The following is a description of a gene set: species: Mus musculus Binds to and modulates the activity of a sodium channel. Mouse Gene Set: GOMF_SODIUM_CHANNEL_REGULATOR_ACTIVITY, and this is the list of marker genes: Fxyd2, Ptpn3, Fgf13, Fgf14, Fxyd6, Scn3b, Nos1, Fxyd3 (FXYD domain-containing ion transport regulator 3), Pcsk9, Fxyd5, Scn4b, Ywhah, Tmprss3, Gpd1l, Scn2b, Fxyd1, Rangrf, Tmem168, Fxyd7, Agt, Nedd4, Atp2b4, Prss30, Nedd4l, Gpld1, Glrx, Prss8, Camk2d, Scn1b, Fgf11, Snta1, Commd1, Fgf12, Sclt1, Cav3, Fxyd4